Given this list of marker genes LSM2, ADH5, PRPF38A, RPS4X, SH2B2, FUS, PPP4C, MAP2K7, CCDC77, COX6A1, PPP1R3C, SFT2D3, CORO7, DHX15, KHDRBS1, RPL4, SLC25A3, SLC39A9, HIGD2A, TPM3, SCARA5, ARHGAP24, BAG3, RPL5, OTOP1, ERGIC3 (ERGIC and golgi 3), RHBDF2, TP53RK, TBC1D9B, HLA-C, IER2 (immediate early response 2), RIPOR1, BCL2A1 (BCL2 related protein A1), HAGH, HEXB, FOS, CALML4, CMTM2, ZBTB8OS, ISY1, PDXK, DBI, CDC14A, PYCR3, CS, NDUFAF6, CFAP107, HOXD8, PIGL (NCBI Gene Id 9487), AIMP2, RASL11B, RPL24, PABPN1, DOK1, TTC21A (tetratricopeptide repeat domain 21A), SUN3, CHEK1, WDR1, FANCF, ATAT1, HSBP1, NPM1, PSPC1, TTLL1, ITGB1BP1, COA5, RIT1 (NCBI Gene Id 6016), TUBA1B, ANKS3, ABCB10, LRRC8C, TMIGD1, EIF2D, KBTBD2, CCT7, DCAF13, ARK2C, DNMBP, HERPUD1, PRKAR1A, CDC42BPG, CFAP161, PROSER1, MRPL45, PHKA1 (NCBI Gene Id 5255), MFSD5 (NCBI Gene Id 84975), ENDOD1, NPRL2, CDK8, PARK7, SMYD4, TUBA1A, SMAP2, C12orf57, WDHD1, PLBD1, API5, LPP-AS2, ITPA, MSTO1, SMAD2, CYB561A3, AMPH, SNRNP70, HLA-B, OBI1, STX16, ATP5MK, NFKB1, STRIP1, SPEF2, TRAPPC6A, SMS, FAM168B, TRMT2A, PPIG, HSPH1, H2AX, ZNF346, EIF5A, GLRX5, TLE1, HNRNPDL, CEPT1, MXD1 (MAX dimerization protein 1), TMA7, RBAK, GSAP, PDSS2, HEMGN, NUF2, PTGR1 (prostaglandin reductase 1), CDADC1, GMFG, BRAP, LY6D, SPART, RAB1A, ZNRF1, SRSF5, EHD4 (NCBI Gene Id 30844), EPHA2, CADPS, RPL7A, CALCR, FAM98C, UBAC1, STUB1, HCK, RACK1, DERL2, C18orf21, TXLNB, C1QBP, EIF4H, PLXNB2, TXNIP, CENPJ, MARVELD1 (NCBI Gene Id 83742), RAB43, VPS35L, ZMYND11, EWSR1, ILF3, NEK3, RGP1, ALDH16A1, KXD1, SRBD1, ETV6, RPS8, UBE2V2, MICAL1, HSPA2, DIMT1, MIF, PRPF6, PSAP, GNAS, R3HDM4, INO80C, CRTAP, DTX2, RBBP7, TMEM107, CTDSP2, SH3RF2, SMIM30, FBXW10, EMP3, UNC5B, PSME3IP1, CCN2, RGS2, MAGED2, ASF1B, PANK4, CCR5, FYB1, HOXB6, here is a description of the gene set: Monocytes mature tom acrophages in the presence of the lineage determining cytokine M-CSF. They can be further polarized into M1 or M2 macrophages with distinct functional properties. We used microarrays to detail the global programme of gene expression underlying macrophage maturation and polarization and identified distinct classes of up-regulated genes during this process. studied in species Homo sapiens Genes down-regulated in monocytes versus classically activated (M1) macrophages. from publication Martinez FO, Gordon S, Locati M, Mantovani A (PMID 17082649) Human Gene Set: GSE5099_MONOCYTE_VS_CLASSICAL_M1_MACROPHAGE_DN